The following is a description of a gene set: studied in species Mus musculus Mouse Gene Set: chr7C, and this is the list of marker genes: Mir344c, Gm18988, Mir344f, B230209E15Rik, Gm7583, A330076H08Rik, Mir344d-1, Gm7656, Gm16158, Fan1, Mir6416, Gm9445, 1700112J16Rik, Gm44691, Altre, Pcsk6, Otud7a, Gm38451, 6030442E23Rik, Lysmd4, Ttc23, Gm32111, Fam169b, Cers3, Mir344d-3, E030018B13Rik, Gm5334, Mir344, A230006K03Rik, Gm3307, Selenos, 4833412C05Rik, Vmn2r-ps61, Asb7, Gm29328, Gm39027, Igf1r, Apba2, Gm22494, Gm7627, Gm35325, Gm10623, Mir344-2, Mir344g, Tars3, Mkrn3, Synm, Gm7551, Mphosph10, Aldh1a3, Gm20684, 1810008I18Rik, Lrrk1, B130024G19Rik, Gm3257, Potefam2, Gm38584, Gm34350, Peg12, Gm9801, Mir344d-2, Mtmr10, Gm5342, Gm33926, Gm34838, Lrrc28, Nr2f2, Snrpa1, Gm17918, Gm44812, Arrdc4, BC046251, Gm5898, Gm32061, Mir344b (microRNA 344b), Gm17909, Gm7546, Gm34549, 4930405G09Rik, Mir211, Atp5l-ps1, Chrna7, 1810049I09Rik, Gm23431, Gm20670, Gm28258, Gm32983, Gm36011, Magel2, 4930554H23Rik (RIKEN cDNA 4930554H23 gene), Nsmce3, Gm29683, Gm23042, Chsy1, Gm44720, 4933436H12Rik, Klf13, Gm23233, Gm24120 (NCBI Gene Id 115485623), Gm35842, Mef2a, Gm32633, Trpm1, Mir344e, Tm2d3, Gm17908, Lins1, Gm42397, Entrep2, Pgpep1l, Gm7482, 4933423L19Rik, Gm34783, Adamts17, Ndn, Mcee, Mir7057, Gm23795, Tjp1, 4930402F11Rik, A230057D06Rik (RIKEN cDNA A230057D06 gene), Gm34664, Gm27252, Gm33570, Gm19032, Ube2nl